The following is a description of a gene set: Human Gene Set: GOCC_PROTEIN_FOLDING_CHAPERONE_COMPLEX A protein complex required for the non-covalent folding or unfolding, maturation, stabilization or assembly or disassembly of macromolecular structures. Usually active during or immediately after completion of translation. Many chaperone complexes contain heat shock proteins. studied in species Homo sapiens, and this is the list of marker genes: CCT8L1P, RUVBL1, RPAP3, PPP5C, BAG3, CCT8L2, RUVBL2, BAG2, STIP1, HSP90AB1, CCT6B, CCT7, CDC37, PTGES3, HSF1, STUB1, PSMG1, CCT3, CCT4, HSPA8, WDR83OS, PDRG1, CCT6A, TSC1, UXT, TCP1, CCT2, SPAG1, DNAJB11, PSMG2, PFDN6, SDF2, CCT8, URI1, DNAAF2, HSPB8, PIH1D2, PFDN2, CCT5, CCDC47, SDF2L1, DNAJC9